The following is a description of a gene set: Pathway Definition from KEGG: IL1 -> IL1R -> MYD88 -> IRAK1/4 -> TRAF6 -> TAB1/2/3 -> TAK1 -> MKK3/6 -> MAPK14 -> MK2 -| TTP IL1-IL1R-p38 signaling pathway. Pathway ID: N00186. Pathway type: Reference. Pathway class: nt06526 MAPK signaling. Human Gene Set: KEGG_MEDICUS_REFERENCE_IL1_IL1R_P38_SIGNALING_PATHWAY species: Homo sapiens, and this is the list of marker genes: TAB1, TAB3, IL1A, ZFP36, MAPK14, IRAK4, IRAK1, IL1R1, TAB2, MAP3K7 (NCBI Gene Id 6885), MAP2K3, MYD88, MAP2K6 (mitogen-activated protein kinase kinase 6), TRAF6, IL1B, MAPKAPK2, IL1RAP